The following is a description of a gene set: studied in species Mus musculus Binding to protein tyrosine kinase. Mouse Gene Set: GOMF_PROTEIN_TYROSINE_KINASE_BINDING, and this is the list of marker genes: Cdh1, Rab8a, Khdrbs1, Pik3r2, Erbb2, Csk, Ceacam1, Ptpn11, Rasa1, Nedd9, Clasp2, Hyal2, Arhgef16, Nck2, Ceacam10, Blnk, Itgb1, Stap1, Gab2, Ptpn14, Gja1, Grb14, Cpne3, Fcrl5 (Fc receptor-like 5), Gprc5b, Shc2, Grin2a, Frs3, Pten, Mst1, Git1, Nrg1, Irs2, Pcna, Psg22, Crk, Irs1, Artn, Gdnf, Grm5, Cadm4, Sirpa, Hsp90aa1, Angpt4, Alkal1, Prr7, Shc3, Sh2b1 (NCBI Gene Id 77601), Ptpn2, Phyhip, Zpr1, Anxa5, Trp53, Plcg2, Epha4, Cblb, Map3k7, Cbl, Itgax, Ptpn22, Elmo2, Plcg1, Fiz1, Cd4, Ywhag, Flt3l, Nrtn, Rack1, Trim6, Rnf41, Rasgrf1, Dusp3, Nr3c1, Grin2b, Nox4, Grb2, Psg18, Tiam1, Tob1, Ptpn1, Tjp2, Dusp22, Angpt1, Nck1, Acvr1, Shc1, Crkl, Jup, Ceacam20, Gas6, Dnaja3, Vim, Pik3r1, Gfral, Cdh5, Dazap2, Shc4, Gp6, Trem2, Pitpnm3, Dock4, Dok2, Cd2, Sh2b3, Psg29, Cblc (Casitas B-lineage lymphoma c), Dscam, Eif3a, Cd247 (NCBI Gene Id 98717), Cass4, Cdh2, Ceacam2, Fnta, Pspn (persephin), Bank1, Sh2d3c, Ptprf, Ctnnd1, Alkal2, Ntrk2, Lrp4, Angpt2, Frs2, Pitpnm2, Tradd, Pitpnm1, Socs5, Bmpr2 (bone morphogenetic protein receptor type 2), Acp4, Myoc, Sh2b2